The following is a description of a gene set: studied in species Homo sapiens Human Gene Set: MIR935 Genes predicted to be targets of miRBase v22 microRNA hsa-miR-935 in miRDB v6.0 with MirTarget v4 prediction scores > 80 (high confidence targets). from publication Chen Y, Wang X (PMID 31504780), and this is the list of marker genes: UGT8, CTBP2, WASHC5, TBC1D15, CAB39, JARID2, NRG1, MAP3K7, CCDC73, FMR1, MRC1, RELN, F11R, IRS2, CLEC14A, TMEM215, PTPRS, GMEB1 (NCBI Gene Id 10691), CRIM1, PRMT3, HEY2, MPV17L2, HDHD2, TRDN, NR2C2, FZD6, GFPT2, RBFOX1, CADPS, ATP1B3, CDC14B, CSF3, HYCC1, GJA9, MYO1B (NCBI Gene Id 92451), SPIN1, PCSK5, TBC1D9, ZNF365, IREB2, TNFAIP8, NOL4, FOXO1, STC1, EFHD1, MYT1, CWC25, MAP7D1, ONECUT2, P2RY13, EEA1 (early endosome antigen 1), LEKR1, CPEB1, HACE1 (HECT domain and ankyrin repeat containing E3 ubiquitin protein ligase 1), MTCL2, PRKG2, ATXN10, ATP6V1B1, SBNO1, AAK1, INO80, DMD, RUBCNL, ZFAND6, MED10, CFAP184, VPS41, ERLIN2, SREK1IP1, SCAI (NCBI Gene Id 286205), SEPSECS, HOMEZ, POU2F1, C5orf24, ANKRD44, GLUD1, RORA (NCBI Gene Id 6095), KALRN, CTSV, HSP90B1, POF1B, KIAA0232, PLEKHH2, SLF2, MPP3, OSBPL11, GOPC, PRR5L, NAP1L2, ARL13B, DLAT, DPY19L1, PUS10, RFX6, PGGT1B, FGL2, NAP1L4 (NCBI Gene Id 4676), BRPF1, RERG, CSNK1G3, PPP4R2, TMEM263, RELCH, FBXW7, RRAS2, ATXN1L (ataxin 1 like), JCHAIN, SLC22A24, ANKRD31, ATP11C, NCOA7, FOXJ3, LMO2, GABARAPL2, HIF1A, SAMD12, MTSS1